Given this list of marker genes LITAF, IRF2BPL, SCO2, TTPA, ABCB7, RIPOR2, CAMTA1, SH3TC2, RFC1 (NCBI Gene Id 5981), OPA3, CLDN9, RNF170, MTTP, RNASEH1, TBP, POU4F1, NEFL, MPV17, TTR, PLS1, FLVCR1, PIK3CD, KNSTRN, MFN2, TWNK (twinkle mtDNA helicase), PLD3 (phospholipase D family member 3), XRCC1, POLG, POLR3A (NCBI Gene Id 11128), PDXK, ITPR1, SPG11, here is a description of the gene set: Human Gene Set: HP_POSITIVE_ROMBERG_SIGN studied in species Homo sapiens Positive Romberg sign The patient stands with the feet placed together and balance and is asked to close his or her eyes. A loss of balance upon eye closure is a positive Romberg sign and is interpreted as indicating a deficit in proprioception.